The following is a description of a gene set: species: Mus musculus Mouse Gene Set: GOBP_PENETRATION_OF_ZONA_PELLUCIDA The infiltration by sperm of the zona pellucida to reach the oocyte. The process involves digestive enzymes from a modified lysosome called the acrosome, situated at the head of the sperm., and this is the list of marker genes: Pithd1, T, Hexb, Ppp3r2, Tnp2, Garin3, B4galt1, Ppp3cc, Garin5b (NCBI Gene Id 243822), Acr, Garin5a, Smcp, Hyal5, Gm773, Garin4, Dkkl1, Garin2, Hyal3